The following is a description of a gene set: Mouse Gene Set: GOBP_RIBONUCLEOSIDE_MONOPHOSPHATE_BIOSYNTHETIC_PROCESS The chemical reactions and pathways resulting in the formation of a ribonucleoside monophosphate, a compound consisting of a nucleobase linked to a ribose sugar esterified with phosphate on the sugar. studied in species Mus musculus, and this is the list of marker genes: Uprt, Uckl1, Umps, Uck1, Impdh1, Ampd3, Dhodh, Gmps, Uck2, Adss2, Dck, Cda (cytidine deaminase), Ada, Upp2, Ampd1, Cad, Gmpr2, Ampd2, Rfk, Paics, Impdh2, Nudt2, Atic, Adss1, Aprt, Pnp, Prps2, Pfas, Upp1, Adk, Gart, Adsl, Hprt1, Gmpr, Ppat, Prps1